Given this list of marker genes SRD5A3, CYP26C1, AKR1B10, BCO1, PLPP6, BCO2, AKR1C3, CYP26A1, CYP2W1, CYP26B1, here is a description of the gene set: The chemical reactions and pathways resulting in the breakdown of an isoprenoid compound, isoprene (2-methylbuta-1,3-diene) or compounds containing or derived from linked isoprene (3-methyl-2-butenylene) residues. studied in species Homo sapiens Human Gene Set: GOBP_ISOPRENOID_CATABOLIC_PROCESS